The following is a description of a gene set: A lighter than expected T2 signal on magnetic resonance imaging (MRI) of the basal ganglia. This term refers to a localized hyperintensity affecting a particular region of the basal ganglia. species: Homo sapiens Focal T2 hyperintense basal ganglia lesion Human Gene Set: HP_FOCAL_T2_HYPERINTENSE_BASAL_GANGLIA_LESION, and this is the list of marker genes: MT-ND3, MT-ATP6, LRPPRC, PDE10A, SCO2, MT-ND6, PRNP, NDUFS4, GFAP, ALG2, MT-TV, PDSS2, ETHE1, TACO1, SPG11, SUCLG1, ASL, MECR (mitochondrial trans-2-enoyl-CoA reductase), MT-TW, MT-ND1, MT-TL1, MT-ND4 (mitochondrially encoded NADH:ubiquinone oxidoreductase core subunit 4), NDUFS1, MT-ND2, MT-ND5, MT-TK